The following is a description of a gene set: Binding to a cyclic AMP response element (CRE), a short palindrome-containing sequence found in the promoters of genes whose expression is regulated in response to cyclic AMP. Mouse Gene Set: GOMF_CAMP_RESPONSE_ELEMENT_BINDING studied in species Mus musculus, and this is the list of marker genes: Atf2, Nr4a3, Atf7, Jdp2 (NCBI Gene Id 81703), Jun, Creb3l1, Hmga2, E4f1, Tcf12, Creb1, Creb3l2, Creb5